The following is a description of a gene set: Mouse Gene Set: GOMF_MITOGEN_ACTIVATED_PROTEIN_KINASE_KINASE_BINDING Binding to a mitogen-activated protein kinase kinase, a protein that can phosphorylate a MAP kinase. studied in species Mus musculus, and this is the list of marker genes: Taok2, Ace, Ksr1, Map3k11, Pin1rt1, Mapk8ip3, Pin1 (peptidyl-prolyl cis/trans isomerase, NIMA-interacting 1), Dusp19, Map3k1, Trib2, Nos1ap, Trib1, Arrb1, Raf1, Mapk8ip1, Trib3, Igbp1, Dab2ip, Braf, Ksr2